The following is a description of a gene set: studied in species Mus musculus Mouse Gene Set: GOBP_CELLULAR_RESPONSE_TO_HIGH_DENSITY_LIPOPROTEIN_PARTICLE_STIMULUS Any process that results in a change in state or activity of a cell (in terms of movement, secretion, enzyme production, gene expression, etc.) as a result of a high density lipoprotein particle stimulus., and this is the list of marker genes: Abcg4, Abca1, Ccl2, Abcg1, Adam17